The following is a description of a gene set: Human Gene Set: PID_ARF_3PATHWAY from publication Schaefer CF, Anthony K, Krupa S, Buchoff J, Day M, Hannay T, Buetow KH (PMID 18832364) Arf1 pathway studied in species Homo sapiens, and this is the list of marker genes: RAC1, USO1, KDELR1, ARFGAP1, CYTH2, CD4 (NCBI Gene Id 920), PIP5K1A, GBF1, AP2A1, COPA, GGA3, ARF1, AP2M1, ASAP1, PLD2, ARFIP2, GOSR2, CLTB, CLTA